The following is a description of a gene set: species: Homo sapiens part of: Diseases associated with O-glycosylation of proteins Co-expression of both protein O-mannosyl-transferases 1 and 2 (POMT1 and POMT2; CAZy family GT39) is necessary for enzyme activity, that is mediating the transfer of mannosyl residues to the hydroxyl group of serine or threonine residues of proteins such as alpha-dystroglycan (DAG1; MIM:128239). DAG1 is a cell surface protein that plays an important role in the assembly of the extracellular matrix in muscle, brain, and peripheral nerves by linking the basal lamina to cytoskeletal proteins. Defects in POMT1 (MIM:607423) results in defective glycosylation of DAG1 and can cause severe congenital muscular dystrophy-dystroglycanopathies ranging from a severe type A, MDDGA1 (brain and eye abnormalities; MIM:236670), through a less severe type B, MDDGB1 (congenital form with mental retardation; MIM:613155) to a milder type C, MDDGC1 (limb girdle form; MIM:609308). Reactome Pathway: Defective POMT1 causes MDDGA1, MDDGB1 and MDDGC1, and this is the list of marker genes: POMT2, DAG1, POMT1